Given this list of marker genes Aadat, Amdhd1, Ftcd, Fpgs, Gclm, Slc25a12 (solute carrier family 25 (mitochondrial carrier, Aralar), member 12), Oat (NCBI Gene Id 18242), Mthfsl, Got2, Bloc1s6, Ggt1, Nr1h4, Got1, Gad1, Atcay, Asl, Dglucy, Gls, Glud1, Gclc, Aldh5a1, Prodh2, Gls2, Aldh4a1, Adhfe1, Prodh, Uroc1, Slc7a11, Nags, Aldh18a1, Gad2, Tat, Hal, Apc, Glul, here is a description of the gene set: studied in species Mus musculus The chemical reactions and pathways involving glutamate, the anion of 2-aminopentanedioic acid. Mouse Gene Set: GOBP_GLUTAMATE_METABOLIC_PROCESS